The following is a description of a gene set: studied in species Homo sapiens G beta:gamma signalling through PI3Kgamma Human Gene Set: REACTOME_G_BETA_GAMMA_SIGNALLING_THROUGH_PI3KGAMMA, and this is the list of marker genes: PIK3CG, GNB2, AKT2, GNG3, PDPK1, GNB5, GNGT2, GNG11, GNGT1, GNB4, GNG4, GNG13, GNG10, AKT3, GNB1, PIK3R6, GNG7, PIK3R5, GNG8, GNB3, GNG12, RHOA, GNG2, GNG5, AKT1